The following is a description of a gene set: Human Gene Set: TRAVAGLINI_LUNG_PLASMACYTOID_DENDRITIC_CELL from publication Travaglini KJ, Nabhan AN, Penland L, Sinha R, Gillich A, Sit RV, Chang S, Conley SD, Mori Y, Seita J, Berry GJ, Shrager JB, Metzger RJ, Kuo CS, Neff N, Weissman IL, Quake SR, Krasnow MA (PMID 33208946) studied in species Homo sapiens, and this is the list of marker genes: NUP210, PPM1J (protein phosphatase, Mg2+/Mn2+ dependent 1J), GAS6, TSPAN13, TGFBI, NRP1, MYBL2, SEC61B, SLC20A1, RRBP1, P2RY14, NR3C1 (NCBI Gene Id 389335), TOX2, APP, PMEPA1, SLC7A5, PFKFB2, GPX1, IRF4, PHEX, AEBP1, CBFA2T3, RNF130, NOPCHAP1, UGCG, SERPINF1, SMPD3, PROC, CDYL, SEL1L3, MAP1A, MCOLN2, CUX2, SCN9A, PLXNA4, NAPSB (napsin B aspartic peptidase (pseudogene)), RNASE6, NIBAN3, MGLL, SPIB, SLC35F3, CXCR3, C12orf75, UNC93B1, MPEG1, CIB2, CD4, ATP13A2, PPP1R14B, SMIM5, CCDC88A, TPM2, SYK, LINC00996, SULF2, CSF2RB, BCL11A, SCAMP5, STMN1, AFF3, GAPT, ZFAT (NCBI Gene Id 57623), CARD11, COBLL1, CYB561A3, GPM6B, RNASET2, ANKRD53, DNASE1L3, PTCRA, EIF2AK4, RUNX2, EPHB1, TCF4, EPHA2 (EPH receptor A2), ST6GALNAC4, PTPRS, KCNK17, ITM2C, RASD1, TNFRSF21, PACSIN1 (protein kinase C and casein kinase substrate in neurons 1), GPR183, TBC1D8, IRF8, CORO1C, ABHD15, PARVB, KRT5, CLEC4C, MZB1, LGMN, DUSP5, SIDT1, EGLN3, SPNS3, LRRC26, THBD, PLD4, DAB2, TAMALIN, TP53I11, TLR7, VASH2, LTK, VEGFB, BMF, FLNB (NCBI Gene Id 8413), SH2B3, LAMP5, CCDC50